The following is a description of a gene set: Human Gene Set: REACTOME_SUMOYLATION_OF_DNA_METHYLATION_PROTEINS SUMOylation of DNA methylation proteins studied in species Homo sapiens, and this is the list of marker genes: DNMT3A, PHC3, PHC2, PCGF2, DNMT1, SCMH1, SUMO1, CBX4, DNMT3B, CBX8, CBX2 (NCBI Gene Id 876), RING1, RNF2, PHC1, BMI1, UBE2I